Given this list of marker genes TUSC3, RAPGEF2, PIM1, SOX5, PRP4K, H2AC20, RRAS2, GAGE12G, HOXB2 (homeobox B2), SEPTIN8, NUP214, CTNNA1, PDLIM5, PLIN2, GAGE12F (NCBI Gene Id 389855), KLF1, here is a description of the gene set: species: Homo sapiens from publication Ray S, Lu Y, Kaufmann SH, Gustafson WC, Karp JE, Boldogh I, Fields AP, Brasier AR (PMID 15155749) Genes up-regulated in HL-60 cells (acute myeloid leukemia, AML) by expression of p210 BCR-ABL fusion protein. Chronic myelogenous leukemia (CML) results from a t(9,22) translocation, producing the p210(BCR-ABL) oncoprotein, a tyrosine kinase that causes transformation and chemotherapy resistance. To further understand mechanisms mediating chemotherapy resistance, we identified 556 differentially regulated genes in HL-60 cells stably expressing p210(BCR-ABL) versus those expressing an empty vector using cDNA macro- and oligonucleotide microarrays. These BCR-ABL-regulated gene products play diverse roles in cellular function including apoptosis, cell cycle regulation, intracellular signaling, transcription, and cellular adhesion. In particular, we identified up-regulation of the inducible form of heat shock protein 70 (Hsp70), and further explored the mechanism for its up-regulation. In HL-60/BCR-ABL and K562 cells (expressing p210(BCR-ABL)), abundant cytoplasmic Hsp70 expression was detected by immunoblot analysis. Moreover, cells isolated from bone marrow aspirates of patients in different stages of CML (chronic, aggressive, and blast crisis) express Hsp70. Expression of p210(BCR-ABL) in BCR-ABL negative cells induced transcription of the proximal Hsp70 promoter. Mutational analysis mapped the major p210(BCR-ABL) responsive element to a high affinity 5'(A/T)GATA(A/G)-3' GATA response element (GATA-RE) that binds GATA-1 in CML cells. The GATA-RE was sufficient to confer p210(BCR-ABL)- and p185(BCR-ABL)-mediated trans-activation to an inert promoter. Short interfering RNA mediated knockdown of Hsp70 expression in K562 cells induced marked sensitivity to paclitaxel-induced apoptosis. Together these findings indicate that BCR-ABL confers chemotherapeutic resistance through intracellular signaling to the GATA-RE element found in the promoter region of the anti-apoptotic Hsp70 protein. We suggest that down-regulation of the GATA-Hsp70 pathway may be useful in the treatment of chemotherapy-resistant CML. Human Gene Set: RAY_TARGETS_OF_P210_BCR_ABL_FUSION_UP